Given this list of marker genes DCTD (dCMP deaminase), AMPD1, APOBEC3G, APOBEC1, GDA, APOBEC3A, CDADC1, AMPD2, APOBEC3F, ADA, LACC1, APOBEC3H, ADARB1, APOBEC3B, APOBEC3C, ADAT3, APOBEC3D, ADA2, ADAT2, ADAR, AMPD3, GNPDA2, RIDA, ADARB2, ADAT1, MAPDA, ZBP1, GNPDA1, CDA, ADAD2, ADAD1, AICDA, APOBEC2, here is a description of the gene set: Human Gene Set: GOMF_DEAMINASE_ACTIVITY Catalysis of the removal of an amino group from a substrate, producing a substituted or nonsubstituted ammonia (NH3/NH2R). species: Homo sapiens